Given this list of marker genes Kdm6b, Rbfox2 (RNA binding protein, fox-1 homolog (C. elegans) 2), Sox4, Nsg1, Smarcd3, Elavl2, Bcl7a, Tmem50b, Kdm1a, Ss18l1, Arid1b, Ppp2r2b, Nsg2, Mtf2, Rimklb, here is a description of the gene set: species: Mus musculus Genes selectively expressed by cells committed to neuronal differentiation beginning in the ventricular zone, in most cases extending into the subventricular zone, intermediate zone, and cortical plate of embryonic day 14.5 mouse cortex. from publication Bedogni F, Hevner RF (PMID 34321999) Mouse Gene Set: HEVNER_VENTRICULAR_ZONE_AND_UP_NEURON_FATE_COMMITTED_CELLS